Given this list of marker genes CNOT1, ZFP36L2, ZFP36L1 (NCBI Gene Id 677), TOB1, CPEB3, ZFP36, TNRC6B, TNRC6C, AGO2, PABPC1, CNOT7, DHX36, here is a description of the gene set: Human Gene Set: GOBP_POSITIVE_REGULATION_OF_NUCLEAR_TRANSCRIBED_MRNA_CATABOLIC_PROCESS_DEADENYLATION_DEPENDENT_DECAY studied in species Homo sapiens Any process that activates or increases the frequency, rate or extent of nuclear-transcribed mRNA catabolic process, deadenylation-dependent decay.